Given this list of marker genes Sgo2a, Ctnnb1, Bub1, Axin2, Naa10, here is a description of the gene set: studied in species Mus musculus Mouse Gene Set: GOBP_REGULATION_OF_CENTROMERIC_SISTER_CHROMATID_COHESION Any process that modulates the frequency, rate or extent of sister chromatid cohesion in the centromeric region of a chromosome.